The following is a description of a gene set: Any process that activates or increases the frequency, rate or extent of the directed movement of charged atoms or small charged molecules into, out of or within a cell, or between cells, by means of some agent such as a transporter or pore. Mouse Gene Set: GOBP_POSITIVE_REGULATION_OF_MONOATOMIC_ION_TRANSPORT studied in species Mus musculus, and this is the list of marker genes: Fhl1, Ifng, Flna, Scn3b, Mylk (NCBI Gene Id 68242), Cox17, Nkx2-5, Ccl12, Snca, Casq1, Actn2, Scn4b, Heph, Calm2, Nlgn3, Dbi, Atp1b2, Ms4a1, Akt1, Ndufa4, Adcyap1r1, Edn3, Trpc3 (transient receptor potential cation channel, subfamily C, member 3), Kcnq1, Cxcr4, Cftr, Abcb1b, P2ry12, Casr, Trdn (NCBI Gene Id 76757), Jph2, Ppp3r1, Wnk3, Bak1, Scn2b, Akt3, Mllt6, Wnk2, Sri, Lrrc55, Chp1, Jak3, Cav1, Cd4, Atp7a, Cxcr3, Dpp6, Gcg, Crhr2, Ccr1l1, Lgals3, Fxyd6, Adora1, Lrrc26, Wnk1, Hbp1, Ahcyl1, Reln, Capn3, Kcne1 (NCBI Gene Id 16509), Gsto1 (NCBI Gene Id 226190), Kcnmb1, Rnf207, Pdgfb, Edn1, Cask, Cxcl10, Stc1, Ano6, P2ry1, Trpc6, Lilra5, Rapgef3, Ppp3ca, Adrb1, Calm1, Cxcl9, Tcaf1, Lhcgr, Chrm1, Ffar1, P2rx1, Ank3, Stk39, Cx3cl1, Oprk1, Cxcl11, Ccl5, Vmp1, Atp2c2, Oga, Atp2a1, Orai1 (ORAI calcium release-activated calcium modulator 1), Ppp3cb, Ikbkb, F2, Plcg2, Xcl1, Mchr1, Ccl3, Cnksr3, Kcnc2, Trpv3, Stim1, Rgs7, Bdkrb1, Atp1b1, Cacnb3, Scn1b, Atpsckmt (NCBI Gene Id 68073), Tesc, P2rx5, P2rx4, Wfs1, Pirt, Kif5b, Atp1b3, Sgk1, Abcb1a, Cntn1, Plcg1, Stac, Wnk4, Grm6, Ntsr1, Pdgfrb, Akap7, Gimap5, Cracr2a, Cacna1d, Lpar3, Lcn2, Cemip, Homer1, F2rl3, Il13, Clec4b1, Lrrc38, Galr2, Hap1 (huntingtin-associated protein 1), Gal, Plcb1, Trpc1, Hspa2, Nos1, Stac2, Cxcl12, Kcnn2, Nherf1, Ednra (NCBI Gene Id 14737), Fxyd2, Trpa1, Nppa, Aplnr, Trem2, Akap5, Prss8, Gnas, Slc9a1, Ppp3r2, Asph, Fgf14, Agtr1a, Drd4, G6pd2, Hcrt, Slc6a4, Fgf13, Arf1, Dmd (dystrophin, muscular dystrophy), Drd1, Fxyd1, Ccr1, Gpr39, Fgf12, Dspp, Amigo1, Plp1, Adrb2, Pkd2, Htt (huntingtin, NCBI Gene Id 319350), Sumo1, Cacna1c, Fxyd4, Coa8, Ctss, Crh, Lrrc52, Ank2, Gper1, Tescl, Nipsnap2, Abcc8, Creb3, Gstm7, Serpine1, Thy1, Strit1 (small transmembrane regulator of ion transport 1), Bax, Kcnip2, Gimap3, Lep, Cldn16, Scn5a, Akap6, Itpr1, Akap9, Isl1, Gjc2, Cacnb2, Pdpk1, Ucn (urocortin), Npsr1, Trpv2, Tacr2, Fxyd3, Dlg1, Cxcl1, Kcne5, Camk2a, Fxyd7, F2r, Kcnh2, Atp2b2, Nherf2, Fxyd5, Grin1, Abl1, Gpd1l, Kcnj2, Atp2b1, Bmp4, Ehd3, Akt2, Nedd4l, Kcnc1, Calm3, Stac3, Tspo, Stimate, Aqp2, Cd19, Trpc4, Ppp3cc, Stim2, G6pdx, Arrb2, P2ry6, P2rx7